Given this list of marker genes MBD4, ATM, FLI1, PRKAR1A, RAD51D, BRCA1, POLE, ERBB2, PTCH1, BMPR1A, TP53, EPCAM, POLD1, ZFTA, OPCML, AKT1, SOX9, ZFPM2, RAD51, PMS2, PALB2, NR5A1, NR0B1 (NCBI Gene Id 8238), WT1, MUTYH, SPRED1, CDH1, KEAP1, GATA4, MAP3K1, SMAD4, MSH2, MSH6, VAMP7, MRE11 (NCBI Gene Id 4361), PMS1, PIK3CA, IDH1, SEMA4A, BRIP1, RABL3, MSH3, WRN, DICER1, EWSR1, DHX37, WWOX, MLH1, NBN, WNT10A, RAD50, PTEN (NCBI Gene Id 8037), PTCH2, STAG3, DHH, SUFU, PALLD, RNF43, CTNNB1, KRAS, PDE11A, RPS20, IDH2, BRCA2, MDM2, CHEK2, TGFBR2, FOXE1, CDKN2A, PRKN (parkin RBR E3 ubiquitin protein ligase), LMNA, FGFR2, SRY, RAD51C, BARD1, here is a description of the gene set: Human Gene Set: HP_OVARIAN_NEOPLASM A tumor (abnormal growth of tissue) of the ovary. species: Homo sapiens Ovarian neoplasm